Given this list of marker genes DYNC2I2, IFT172, WDR35, DYNC2I1, WDR19, NEK1, here is a description of the gene set: studied in species Homo sapiens Thoracic dysplasia Human Gene Set: HP_THORACIC_DYSPLASIA